The following is a description of a gene set: The BBSome is a stable complex consisting of 7 Bardet-Biedl proteins (BBS1, BBS2, BBS4, BBS5, BBS7, BBS8 - also known as TTC8- and BBS9) and BBIP10 that has roles in promoting IFT and trafficking proteins to the cilum. The BBSome is the primary effector of ARL6/BBS3, a small GTPase that binds the BBSome in complex with associated membrane proteins that are destined for the ciliary membrane. Components of the BBSome are enriched in TPR and beta-propeller motifs and are thought to form a linear coat on membranes that functions with ARL6 to target proteins to the cilium. Reactome Pathway: BBSome-mediated cargo-targeting to cilium part of: Cargo trafficking to the periciliary membrane studied in species Homo sapiens, and this is the list of marker genes: TTC8, ARL6, CCT5, CCT8, CCT4, BBS5 (NCBI Gene Id 428), SSTR3, BBS2, SMO, BBS1, BBS4 (NCBI Gene Id 585), BBS10, RAB3IP (NCBI Gene Id 64325), BBS7, TCP1, MCHR1 (NCBI Gene Id 2847), CCT3, CCT2, MKKS, LZTFL1, BBS12, BBIP1, BBS9